The following is a description of a gene set: Human Gene Set: GOBP_ASPARTATE_FAMILY_AMINO_ACID_BIOSYNTHETIC_PROCESS species: Homo sapiens The chemical reactions and pathways resulting in the formation of amino acids of the aspartate family, comprising asparagine, aspartate, lysine, methionine and threonine., and this is the list of marker genes: MTR (NCBI Gene Id 4548), ADI1, BHMT2, ASNSD1, GOT2, PLOD3, GOT1L1, GOT1, ASNS, BHMT, MTRR, ENOPH1, MTHFD1 (methylenetetrahydrofolate dehydrogenase, cyclohydrolase and formyltetrahydrofolate synthetase 1), APIP, PLOD2